Given this list of marker genes HIC1, PSMB8, RSPO2, SEC61A1, AKT3 (AKT serine/threonine kinase 3), DHX38, EHBP1, RPL24, RAB18, ATP5MF, PM20D1, CFL1, USP4, P2RX4, LGALS1, ZFYVE19, RPL41, RPN2 (ribophorin II), RPS29, IGHM, SMARCD2, HDLBP, RPL13, PPP1CA, CSNK2B, RPS15A, RPS3A, RPS5, FAM169A, GMEB1, EIF4A1, ENO1, ABCC3, SERBP1, RPL10, UBC, ENO3, SORCS2, RPL4, ARPC2, LDHA, POLR3K, RPS16, TUBA1B, RPL5, MORF4L1, RPL18, SEC61B, RPL35, CPSF3, USP8, ALG9, RPL12, PDCD10, IL2RB, COX7A2, BUB3, RPL22, RPL31, RPL17, EAF2, PKM, BLTP2, LMNB2, SFT2D2, SNHG6, PABPC1, RPS14, RPL36A, EEF2, CHCHD2, SRP19, RPL23, LRRC46, UBE2V1, RPS10, HSP90AB1, ARF6, RPL34, PIGK, NFATC4, EDC4, RPL3, NT5E, MRPL10, GZMA, TPT1, ARL4A, ADAM19, ATP5PB, RPL38, TRMT1L, AMFR, MIF, RAP1B, RPL19, GNE (glucosamine (UDP-N-acetyl)-2-epimerase/N-acetylmannosamine kinase), COX5A, UBAC2, PIM1, TTC19, AGO2, SON, RNF187, ARF1, XPNPEP1, PYROXD1, EIF3E, KXD1, CORO1A, PHAX, CALB1, ENPP4, HNRNPC, RPL27A, TMEM45A, ATMIN, YBX1, RPS11, VTA1, RPL11, WNK1, RPS18, B2M, SRGN (serglycin), RPL6, ATOX1, COX6C, CKS1B, RPL27, PRKD1, VIM, TUBB, SRSF5, MYL10, RPS4X, RIPK4, NDST1, DDX5, KRT33A, SSBP1 (single stranded DNA binding protein 1), HK2, DHRS3, GOT2, FAM118A (family with sequence similarity 118 member A), RPS7, ITGA4, NAP1L4, ADPRH, ZFAND5, PLEKHA6, RPA1, STRA6, RPL37A, MRPL43, CHRNA5, COX17, HMGB1, RPS6, RPS23, RACK1 (NCBI Gene Id 90938), EN1, RPLP1, PEX5L, PGK1, RPS8, RPS3, CD8A, NGDN, DCAKD, P2RX7, GOSR2, RPL9, RPL26 (NCBI Gene Id 6154), ZFP92, INCENP, FPR1, RPS26, ACTG1, IFT57, HSP90AA1, PPP1CC, PRKAR1A, CCND2, RPSA, EIF4H, FKTN, PEBP1, FAU, UQCR11, SUCO, NDUFB5, GZMB, RPLP0, COX6A1, SMC5, RPL23A, SNAI2, PPIA, GABPA, here is a description of the gene set: CD8+ T cells play a crucial role in the clearance of intracellular pathogens through the generation of cytotoxic effector cells that eliminate infected cells and long-lived memory cells that provide enhanced protection against reinfection. We have previously shown that the inhibitor of E protein transcription factors, Id2, is necessary for accumulation of effector and memory CD8+ T cells during infection. Here we show that CD8+ T cells lacking Id2 did not generate a robust terminally-differentiated KLRG1hi effector population, but displayed a cell-surface phenotype and cytokine profile consistent with memory precursors, raising the question as to whether loss of Id2 impairs the differentiation and/or survival of effector-memory cells. We found that deletion of Bim rescued Id2-deficient CD8+ cell survival during infection. However, the dramatic reduction in KLRG1hi cells caused by loss of Id2 remained in the absence of Bim, such that Id2/Bim double-deficient cells form an exclusively KLRG1loCD127hi memory precursor population. Thus we describe a role for Id2 in both the survival and differentation of normal CD8+ effector and memory populations. Genes down-regulated in KLRG1 low CD8 T effector cells during infection: ID2 knockout versus ID2 and BCL2L11 knockout. studied in species Homo sapiens Human Gene Set: GSE41978_ID2_KO_VS_ID2_KO_AND_BIM_KO_KLRG1_LOW_EFFECTOR_CD8_TCELL_DN from publication Knell J, Best JA, Lind NA, Yang E, D'Cruz LM, Goldrath AW (PMID 23325888)